The following is a description of a gene set: studied in species Homo sapiens Genes in the cancer module 191. Human Gene Set: MODULE_191, and this is the list of marker genes: LTF, CCL2, XCL1, CCL14, CCL11, CCL3, TF, CCL7, HFE, CP, FTH1, STC1, CCL13, CCL19, MT2A, TFRC, CCL23, MYC, CXCL12